The following is a description of a gene set: Genes down-regulated in CD4 T conv over-expressing XBP1 versus XBP1 and FOX3P. Human Gene Set: GSE40274_XBP1_VS_FOXP3_AND_XBP1_TRANSDUCED_ACTIVATED_CD4_TCELL_DN species: Homo sapiens from publication Fu W, Ergun A, Lu T, Hill JA, Haxhinasto S, Fassett MS, Gazit R, Adoro S, Glimcher L, Chan S, Kastner P, Rossi D, Collins JJ, Mathis D, Benoist C (PMID 22961053) The transcription factor FoxP3 partakes dominantly in the specification and function of FoxP3+ CD4+ T regulatory cells (Tregs), but is neither strictly necessary nor sufficient to determine the characteristic Treg transcriptional signature. Computational network inference and experimental testing assessed the contribution of several other transcription factors (TFs). Enforced expression of Helios or Xbp1 elicited specific signatures, but Eos, Irf4, Satb1, Lef1 and Gata1 elicited exactly the same outcome, synergizing with FoxP3 to activate most of the Treg signature, including key TFs, and enhancing FoxP3 occupancy at its genomic targets. Conversely, the Treg signature was robust to inactivation of any single cofactor. A redundant genetic switch thus locks-in the Treg phenotype, a model which accounts for several aspects of Treg physiology, differentiation and stability., and this is the list of marker genes: HEATR1, UBQLN4 (ubiquilin 4), TIA1, FMNL3, SET (SET nuclear proto-oncogene), NIM1K, LRRC42, GANAB, KDM6B, DIPK1B, GNB1L, GSPT1, PIP4K2A, BYSL, MACROD1, TTC7B, BASP1, TSC22D1, ZMYM4, PROSER1, ATXN2, AGO1, DDX39A, GPATCH4, ARHGEF9, STRIP2, EHMT1, TRIM28, HACD1, CCR9, METAP2, NIBAN3, FUBP3, COLQ, CLUH, KIFC3, RAI1, TMEM120B, NR4A3 (nuclear receptor subfamily 4 group A member 3), HNRNPD, SPATA6, WBP4, SLC9A1, PKDCC, RPL31, ZNF629, MED23, LSM14B, DKC1, GPN1, GAR1, NFKBID, EIF2S3 (eukaryotic translation initiation factor 2 subunit gamma), ZMYM3, NUTF2, OLFML3, TMCC3, SLC16A6, CTSW, PDE7B, DDB1, POGZ, SLC7A1, INTS3, KIT, UBE2E2, RASL11B, PPA1, WBP1L, ADSL, THEMIS, RRP12, KHSRP, NR4A1, XYLT2, INPPL1, ZFP30, FOSL2, ARHGAP20, PDCD5, ODF2L (NCBI Gene Id 57489), MTREX, URB2, LXN, ANP32B, ARHGAP39, ABL1, RANBP1, BCAT1, ACTN1, ZAP70, LYAR, LMO4, GSN, MED14, CCDC88A, SLC22A17, PHB2, XRCC6, JMJD4, CCR7, TET1, SLC7A6, JAK2, FIBCD1, INTS2, SLC35A1, PSMD6, TTLL12, CNOT7, CTPS1, ZNF22, PUS7L, LRFN4, CEP78, TAF2, SRM, SEMA4C, TNFSF4, DDX19A, LANCL1, SNHG32, TGIF2, ETS2, PPIA, RRS1, MAGED1, TYW3, CBX3, WDR12, WDR4, METTL1 (NCBI Gene Id 4234), ODC1, TNFRSF19, PWP2, DLEU7, MTX1, ZCCHC12, NMNAT1, CLPB, AKAP1, HOMER3, GPSM1 (NCBI Gene Id 94330), CCT6A, TMA16, SEH1L, ABCD3, BBS5, NYAP1, PEX5, EMILIN1, CDIP1, B4GALNT1, ZBED5, ZNHIT6, NDUFAF4, PYROXD2, GSTCD, PELP1, RGS12, TUBB, ARMCX2, SANBR, IL21, ADCY6, BACH2, ALDH7A1, TCF7, SNHG6, CACNB3, ADAMTSL2, SLC16A10, TRMT1, CAPRIN1, CDK2AP1, MECR, ARMCX1, GPAA1, TFDP1 (transcription factor Dp-1), OPA3, UBE2E3, SLC35D3, NETO2, KDM2B, EHD3 (NCBI Gene Id 30845), PFKM, CHD1, DUSP5, DENND3, MRPL22, IPO11, ADH1C, ABCG2, NRGN (NCBI Gene Id 4900), CTIF, PTGIR, TTC3, SMYD2